The following is a description of a gene set: species: Homo sapiens Human Gene Set: MODULE_72 Testis genes., and this is the list of marker genes: OAZ2, METAP1 (methionyl aminopeptidase 1), DNALI1, SF3A2, GPRC5B, CAV1, MYL9, PPP4R1, CDR2, MYLK, COPB1, POLE3, COL15A1, USP9X, GTF2E2, TPX2, ZNHIT3 (NCBI Gene Id 9326), RAB11FIP5, PTN, RBCK1, TNPO1, ITGA6, NFKBIB, RNF4, CDK16, ELAVL2, SRP19, MDM1, CSE1L, NUP93, PCNA, AKAP12, EWSR1, GSTA4, UBXN1, PPP2R5D, PDGFRB, KHDRBS3, KATNB1, ECHS1, CLEC3B, ABCD3, GSTM1, SP3, IGFBP2, CKS2 (NCBI Gene Id 1164), CREM, GJA1, SSBP1, COPS5, ABHD2 (NCBI Gene Id 654057), DHX30, CHN1 (chimerin 1), AKAP3, PRAME, TFDP1, COL1A2, AEBP1, CFD, FGFR1, PEG3, MRPL47, GAGE12F, ZYX, PARP2, SRSF2, SRP54, MAPK6, FOXG1, CSNK2A1, HMGXB4 (HMG-box containing 4), PSMA3, SLC16A3, ZCCHC14, TSPYL2, OR7E12P, TCEAL4 (transcription elongation factor A like 4), PRPF6, PSMC2, RBBP4, SAFB2, GCC2, PEG10, IMMT, SRRM2, TLK1, PCOLCE, BIRC2 (NCBI Gene Id 329), CDKN3, PTOV1, CCP110, NSF, RBP1, MOK, GFPT1, GMPS, PSMD4, DENND2B, MICAL2, HMOX2, LSM3, SCCPDH, CYB5R1, TCFL5, COPS2, SLBP, ENG, SMARCA4, RBMXL2, PRB4, DLK1, STMN1, SGCE, PCYT2, FLNA, TYMS, MCM6, TRIM16, NEK2, PTPN12, LSM14A, SLC1A6, TFRC, SF3A1, CEBPZ (NCBI Gene Id 10153), ITPR3, HSPA2, INTS1, PSMA4, MFAP2, DHX9, CADM1, CBX1, ENPP2, KCTD17, ZBTB20, TPM2, DGUOK, TPM1, C7, C1S, ABLIM1 (actin binding LIM protein 1), SNRPF, CITED1, FAT1, TMX4, RASSF2, GET1, APOE, BUD23, AIMP2, UGCG, CCNB2, MYH11, SLC2A5, SEPTIN6, SMARCA2, EPB41L3, WFS1, ZWINT, KDM1A, TSC2, IK, SMARCA1, KLHDC3, FKBP8, TRIP13, ELAC2, ZIC2, RNF167, RAB11A, H2BC12, IFI27, CKAP5, CHGA, PLAAT3, FHL2, FBLN2, BTG3, LPAR2, MYL6B, POMZP3, IP6K1, CBX3, PENK, PRKCI, MAPRE1, SRSF5, ALDH1A1, SYNGR4, PLCG1, ATP6V0D1, TRIB2, NECAB3, KIF5C, SERPINH1, PAIP1, DYRK1A, RAB31, CFAP410, ADIPOR2, DDX39A, SAC3D1, DNM2, TTK, DDX1, IGFBP4, MSMO1, PIK3R3, TSPYL4, SNW1, PLK1, CALB2, ARPP19, TSG101, PLP1, DLX4, PAICS, HOPX, RO60, CCHCR1, DDX3Y, CXADR, SFRP1, FADS1, RANGAP1, PKMYT1, DDX42 (NCBI Gene Id 11325), EXD2 (exonuclease 3'-5' domain containing 2), MAPK8IP3, HNRNPA0, TRAM2, SMC3 (NCBI Gene Id 9126), GTF2A2, TOP2A, ZBTB18 (zinc finger and BTB domain containing 18), PTGDS, SLC7A5, KIF2C (kinesin family member 2C), C5orf15, PRPSAP1, COL6A2, NAE1, GATM, GAGE12G, UBE4A, FOXJ3, ULK1, MRPL3, DNMT1, CDC34, CRIM1, POLRMT, UBE2N, EEF1E1, HSF2, CHPF, SNRPB2, NFE2L2, ARL4A, HSF1, SNRPA1, FSTL3, TOMM34, MCM2, DAP3, TSPAN3, SEC24C, COPS3 (COP9 signalosome subunit 3), INHBB, MSI1, MPI, TMED3, SNRPC, ACD, CPE, SUZ12, UTP18, HDDC2 (NCBI Gene Id 51020), GOLGA8A, KDM5B, CCNA1, GTF3C1, CDC20, DNAJB2, TRIP12, TYRO3, SPINK2, MTMR6, BRD8, QSOX1, MAGEA4, JARID2, CDH2, HPRT1, WDR45B, GYG1, HAGH, YPEL1, SOD3, PSMD14, UBE2M, LRPAP1, APOM, RCN2, PSMG1, SCP2, PTTG1, SOX9, APBB3